The following is a description of a gene set: This event has been computationally inferred from an event that has been demonstrated in another species.<p>The inference is based on the homology mapping from PANTHER. Briefly, reactions for which all involved PhysicalEntities (in input, output and catalyst) have a mapped orthologue/paralogue (for complexes at least 75% of components must have a mapping) are inferred to the other species. part of: Apoptotic factor-mediated response species: Mus musculus Reactome Pathway: SMAC, XIAP-regulated apoptotic response electronically inferred by orthology from the curated human pathway, and this is the list of marker genes: Casp7, Casp3, Septin4